Given this list of marker genes MYL7, SOS2, ACTN3, TNNC2, PVALB, here is a description of the gene set: from publication Chemello F, Bean C, Cancellara P, Laveder P, Reggiani C, Lanfranchi G (PMID 21364935) studied in species Mus musculus Genes down-regulated in type 2B (EDL) vs type 1 (soleus) myofibers. BACKGROUND: Skeletal muscle is a complex, versatile tissue composed of a variety of functionally diverse fiber types. Although the biochemical, structural and functional properties of myofibers have been the subject of intense investigation for the last decades, understanding molecular processes regulating fiber type diversity is still complicated by the heterogeneity of cell types present in the whole muscle organ. METHODOLOGY/PRINCIPAL FINDINGS: We have produced a first catalogue of genes expressed in mouse slow-oxidative (type 1) and fast-glycolytic (type 2B) fibers through transcriptome analysis at the single fiber level (microgenomics). Individual fibers were obtained from murine soleus and EDL muscles and initially classified by myosin heavy chain isoform content. Gene expression profiling on high density DNA oligonucleotide microarrays showed that both qualitative and quantitative improvements were achieved, compared to results with standard muscle homogenate. First, myofiber profiles were virtually free from non-muscle transcriptional activity. Second, thousands of muscle-specific genes were identified, leading to a better definition of gene signatures in the two fiber types as well as the detection of metabolic and signaling pathways that are differentially activated in specific fiber types. Several regulatory proteins showed preferential expression in slow myofibers. Discriminant analysis revealed novel genes that could be useful for fiber type functional classification. CONCLUSIONS/SIGNIFICANCE: As gene expression analyses at the single fiber level significantly increased the resolution power, this innovative approach would allow a better understanding of the adaptive transcriptomic transitions occurring in myofibers under physiological and pathological conditions. Human Gene Set: CHEMELLO_SOLEUS_VS_EDL_MYOFIBERS_DN